Given this list of marker genes MST1P2, CBX8, SSBP3P5, DDX11L5, CROCCP2, SLC35B2, DHRS2, RNA5SP528, H2AC20, TERF2, ENSG00000232581, BMS1P17, INTS15, H2BC21, DCAF4, EHMT2, BOLA1, FSCN1, DDX11L10, SUGCT, EEF1A1, LINC02228, LRWD1, MIR4273, LRATD2, ZNF853, SLC2A14, KAT2A, ORC3, STK38L, GNG4, MCPH1-AS1, SNX16, GRID2IP, DHX58, LINC02211, RFWD3, MPLKIP, HSPB9, CDT1, RADIL, THOC6, GRK1, MIR1302-3, ABHD17AP4, PYCARD, EEF1D (NCBI Gene Id 87167), HSF5, PDPR, RAPGEF1, VEZF1, HCFC1R1, TLN1, here is a description of the gene set: Genes containing one or more binding sites for (SQSTM1) in their promoter regions (TSS -1000,+100 bp) as identified by GTRD version 20.06 ChIP-seq harmonization. Human Gene Set: SQSTM1_TARGET_GENES species: Homo sapiens from publication Yevshin I, Sharipov R, Kolmykov S, Kondrakhin Y, Kolpakov F (PMID 30445619)